Given this list of marker genes Gmds, Slc35c1, Fcsk, Gfus, Fuom, Fpgt, here is a description of the gene set: species: Mus musculus Mouse Gene Set: REACTOME_GDP_FUCOSE_BIOSYNTHESIS GDP-fucose biosynthesis